The following is a description of a gene set: studied in species Mus musculus Any process that increases the rate, frequency, or extent of the series of events that restore integrity to a damaged tissue, following an injury. Mouse Gene Set: GOBP_POSITIVE_REGULATION_OF_WOUND_HEALING, and this is the list of marker genes: Reg3a, Emilin2, Arfgef1, Ptk2, Tmem97, Mtor (NCBI Gene Id 80612), St3gal4, Reg3g, Duox1, Serpinf2, Cldn1, Enpp4 (NCBI Gene Id 224794), Fermt1, Hmgb1, Vwf, Plat, Hras, Prkce, Insl3, Apoh, F7, Dmtn, F2, Anxa1, F2r, Adra2a, S100a9, Plg, Xbp1, Ccn4, Hif1a, Ptger4, Tbxa2r, Thbs1, Nfe2l2 (nuclear factor, erythroid derived 2, like 2), Hrg, Ano6, Prdx2, Clec7a, Hpse, Serpine1 (NCBI Gene Id 231790), Ddr2, Mylk, F12, Ccl2, Actg1, Hbegf, Rreb1, Plau, Itgb1, Vegfb, Cldn3, Emilin1, Vtn (vitronectin), Foxc2, Cxcr4, Kank1, Cd36, Cpb2 (NCBI Gene Id 93820, carboxypeptidase B2), Cldn13, Smoc2, Cldn4, Duox2, Fermt2